The following is a description of a gene set: species: Mus musculus Mouse Gene Set: MATZUK_SPERMATOGONIA from publication Matzuk MM, Lamb DJ (PMID 18989307) Genes important for spermatogonia, based on mouse models with male reproductive defects. Reproduction is required for the survival of all mammalian species, and thousands of essential 'sex' genes are conserved through evolution. Basic research helps to define these genes and the mechanisms responsible for the development, function and regulation of the male and female reproductive systems. However, many infertile couples continue to be labeled with the diagnosis of idiopathic infertility or given descriptive diagnoses that do not provide a cause for their defect. For other individuals with a known etiology, effective cures are lacking, although their infertility is often bypassed with assisted reproductive technologies (ART), some accompanied by safety or ethical concerns. Certainly, progress in the field of reproduction has been realized in the twenty-first century with advances in the understanding of the regulation of fertility, with the production of over 400 mutant mouse models with a reproductive phenotype and with the promise of regenerative gonadal stem cells. Indeed, the past six years have witnessed a virtual explosion in the identification of gene mutations or polymorphisms that cause or are linked to human infertility. Translation of these findings to the clinic remains slow, however, as do new methods to diagnose and treat infertile couples. Additionally, new approaches to contraception remain elusive. Nevertheless, the basic and clinical advances in the understanding of the molecular controls of reproduction are impressive and will ultimately improve patient care., and this is the list of marker genes: Cdkn2d, P2rx1, Cyp19a1, Kit, Sohlh2, Utp14b, Bax, Nanos2, Rhox5, Dnmt3l, Dazl, Bmp8b, Csf1, Gdnf, Etv5, Zbtb16, Limk2, Pin1, Adamts2, Ddx4, Apaf1, Sycp2, Stra8, Rbp4, Slc19a2, Gja1